The following is a description of a gene set: Human Gene Set: GAVISH_3CA_METAPROGRAM_B_CELLS_INTERFERON from publication Gavish A, Tyler M, Greenwald AC, Hoefflin R, Simkin D, Tschernichovsky R, Galili Darnell N, Somech E, Barbolin C, Antman T, Kovarsky D, Barrett T, Gonzalez Castro LN, Halder D, Chanoch-Myers R, Laffy J, Mints M, Wider A, Tal R, Spitzer A, Hara T, Raitses-Gurevich M, Stossel C, Golan T, Tirosh A, Suvà ML, Puram SV, Tirosh I (PMID 37258682) studied in species Homo sapiens Genes upregulated in subsets of cells of a given type within various tumors In this study, an extensive analysis was conducted to define meta-programs (MPs) capturing intra-tumor heterogeneity across a spectrum of tumor types. The approach utilized non-negative matrix factorization (NMF) to analyze each cell type separately within individual tumor samples. This involved the analysis of malignant cells, macrophages, fibroblasts, endothelial cells, epithelial cells, T-cells, and B-cells. NMF was executed with varying parameter values (K=4, 5, 6, 7, 8, 9), thereby generating 39 programs for each cell type per sample. Each NMF program was summarized by the top genes based on NMF coefficients.\nRobust MPs were then delineated for each cell type using a set of stringent criteria, including recurrence within the same tumor, similarity to programs in other tumors, and non-redundancy within a tumor. Subsequently, these robust NMF programs were clustered (per cell type) based on Jaccard similarity, leading to the identification of MPs associated with each cell type.\nTo enhance the quality of the MPs, a refinement steps were undertaken, involving the removal of MPs suspected of reflecting low-quality data (with an overrepresentation of ribosomal proteins or mitochondrial-encoded genes), single-study inclusion, or similarity to miss-annotated cell types., and this is the list of marker genes: HERC5, IRF7, APOL6, IFIT3, DYNLT1, USP18, BST2, EIF2AK2, IFI35, IFIT2, TAP1, CMPK2, EPSTI1, OAS1, LAP3, MT2A, IFI44L, RABGAP1L, GBP4, IFIT1, RNF213, MNDA, GBP1, LY6E, TRIM22, OAS3, ISG15, PARP9, MX2, IFI44, NT5C3A, NMI, MX1, ISG20, IFITM1, SAMD9L, SAMD9, IFI6, SLFN5, CHST12, SOCS1, OAS2, PARP14, STAT1, UBE2L6, XAF1, PLSCR1, TNFSF10, PPM1K, RSAD2